Given this list of marker genes Arid1a, Usp40, App, Ndrg3, Pnrc1, Crebzf, Serpinb8, Rin2, Fbn1, Abtb2, Zfp36l2 (NCBI Gene Id 12193), Ppp1r14c, Tbl1xr1 (transducin (beta)-like 1X-linked receptor 1), Abcg3, Tfap4, Pura, Mef2a, Phf3, Dipk2a, Gm15107, Abcc5, Sh2d3c, Ppfia1, Morc3, Ammecr1, Hnf1b, Il13, Gpcpd1, Atp2b1, Eif5, Togaram1, Tia1, Tet2 (tet methylcytosine dioxygenase 2), Med13, Baz2b, Pcdh7, Afap1, Rock2, Ankrd17 (NCBI Gene Id 81702), Sox6, Panx2, Fos, Tulp4, Zfhx3, Phlda1, Irx2, Trpc4, Clca3b, Map3k13, Zfp120, Nek7, Tnrc6b, Efr3a, Cdyl (NCBI Gene Id 12593), Cadm2, Tet1, Stc1, Nfasc, Gcnt2, Naa15, Nacc2 (NCBI Gene Id 98968), Sox13, Lmtk2, Rai1, Hsf3, Rap2c, Mbnl3, Ezh2 (enhancer of zeste 2 polycomb repressive complex 2 subunit), Nlk, Irs1, Hapln1, Mycn, Slc4a4, Kpna3, Tspan8, Zeb1, Kat6a, Phf6, Zdhhc21, Nfe2l2, Glrb, Cxxc4, Tgif2, Epn2, Sumo3, Pptc7, Pi15, Nrp1, Zbtb41, Mark1, Scamp1, Adamts17 (NCBI Gene Id 767813), Smap1, Gm15127, Epm2aip1 (NCBI Gene Id 77781), Atp5mc2, Etv1, Cpeb1, Sgk1 (serum/glucocorticoid regulated kinase 1), Cilk1, Pfkfb2, Elk3, Ankrd12, Fbn2, Qki, Gnpda2, Camsap2, Efnb2, Slc6a14, Med12l, Strn3, Aspn, Samd8, Get4, Gm15097, Sval3, Fgd6, Fryl, Tfb2m, Cftr (NCBI Gene Id 547216), Hccs, Lrat, Myo1e, Zfhx4, Rnf111, Flrt3, Zbtb34, Smad2, Arid4b, Gm15093, Atp6v1a, Sec24a, Magi1, Meis2, Pou2f1, Pip4p2, Pip5k1b, Acsl4, Ube3a, Trmt2a, Nfxl1, Greb1l, Ap1g1, Fmr1, Plekhg1, Gm15091, Ylpm1, Nr1d2, Ehmt1, Zc3h11a, Nid2 (NCBI Gene Id 18074), Pafah1b1, 4930402K13Rik, Capza2, Phtf2, Zfp804a, Kif2a, Teddm1b, Rab5a, Man1c1, Bzw1, Rab39b, Taf4, Rarb, Erbin, Snn, Ptpn9, Rgs17, Mpzl2, Mapk6, Sall1, Trim68, Metap1, E2f8, Emp2, Megf9, Zbtb18, Ino80d, Dcbld2 (discoidin, CUB and LCCL domain containing 2), Gja1, Ctdspl, Tspan12, Arsj, Dip2b, Slc10a2, Mycl, Sik2, Klf12, Manea, Mbnl1, Ralgps1, Fam76b, Cdc14a, Bicd2, Prpf4b, Lin54, Itgb1, Mitf, Clpx, Trub1, Gclc, Id4, Letmd1, Sp4, Dr1, Map3k4, Robo2, Scn1a, Plxnc1, Tmtc3, Acvr2b, Ranbp9 (NCBI Gene Id 56705), Phf20 (NCBI Gene Id 228829), Shisa6, Dmd, Prr11, Ube2d1, Begain, Setd5, Eogt, Htra3, St6galnac3, Oosp3, Trio, AU015228, Trim2, Kat6b, Ipo8 (NCBI Gene Id 50504), Ro60, Prpf39, Cpeb2, Med14, Thap1, Tshz3, Pth, Sap30l, Map7d1, Nsd1, Igip (IgA inducing protein), Cct6a, Otud4, Golga4, Aktip, Pbx3, Slc4a10 (NCBI Gene Id 94229), Cdh6, Dennd5a, Zfp800, Sntg1, Cnot9, Phf20l1, Amn1, Creb1, Fam204a, Adamts20, Elovl5, Kifc5b, Brpf1, Trim44 (tripartite motif-containing 44), Lrrc39, Atad2b, Runx1, Tle1, Purb, Gm15080, Rfx3, Fut9, Ubr3, Neurod1, Mybl1, Scn8a, Bmpr1b, Paxbp1, Ptx3, Trappc8, Atxn1, Kif3c, Fam168a, Zfp367, Cdk17, Zcchc2, Arg2 (NCBI Gene Id 11847), Sorcs3, Nrk, Eea1, Ppp1r13b, Cav3, Selenoi, Afdn, Itprid2, Usf3, Ppp2r2a (NCBI Gene Id 71978), Cts3, Thsd7a, Mtmr2, Crebrf, Atp1b1, Cdk8, Kif1b, Sgcg, Rimklb, Gm15085, Rasd2, Ott, Rasl11a, Axin2, Gm15114, Skor1, Mdfi, Slc25a3, Etnk1, Fzd6, Mgat4a, Idh2, here is a description of the gene set: Genes predicted to be targets of miRBase v22 microRNA mmu_miR_101b_3p in miRDB v6.0 with MirTarget v4 prediction scores > 80 (high confidence targets). species: Mus musculus from publication Chen Y, Wang X (PMID 31504780) Mouse Gene Set: MIR_101B_3P